The following is a description of a gene set: Human Gene Set: MIR3714 from publication Chen Y, Wang X (PMID 31504780) Genes predicted to be targets of miRBase v22 microRNA hsa-miR-3714 in miRDB v6.0 with MirTarget v4 prediction scores > 80 (high confidence targets). species: Homo sapiens, and this is the list of marker genes: ARNT2, RCOR1, NUFIP1, PARP16, SLC46A3, USP14, RBM39, ELAPOR2, APLF, HPGD, ELOVL1, SELENOI, SLC35D1 (NCBI Gene Id 23169), RYBP, DENND1B, RHBDL3, RNF216, TTL, SLC31A2, DESI1 (NCBI Gene Id 91610), CSNK1G1, CBLB, PAXBP1, MYO10, RWDD4, SETD3, TMED1, MYLIP, EXTL3 (NCBI Gene Id 2137), ZNF706, SLC9B2, DMD, PAPSS2, FKBP15, SPAG9 (sperm associated antigen 9), SLC4A8, MFSD14B, VAT1L, ADAMTS9, VAT1, THSD7B, ASCL1, BTG2, MTPN, CHSY1, PHACTR1, RALGPS2, PTHLH, ERMP1, FERMT2, QKI, CAPN2, CSTF3, TCTN3, AK4, THUMPD3, SURF4, ACSL1 (acyl-CoA synthetase long chain family member 1), ANXA7, PIEZO2, RTCB, BCL2L11, GPR158, SAP30L, HMBOX1, SEMA6A, NEMP2, PDLIM5, TMCC3, MCUR1, MC2R, GRID1, CBL (NCBI Gene Id 867), PTPN9, SLITRK6, FAM78A, SNX30 (NCBI Gene Id 401548), FIZ1, CACNB4, ZNF559, DCUN1D3, PTBP2, NOTCH1, SCP2, SH2B3, GK5 (NCBI Gene Id 256356), RBFOX2, GLT8D1, SCML4, CDKN2A, ZNRF3, DEPTOR, KATNA1, SLC50A1, SETBP1, ATMIN, GXYLT1, EPM2AIP1, RLIM, COL4A1, FBXO33, SLC9A6, RFX3, PABIR2, TXNDC9, UBR5, DPYSL2, MARK1, MYH9, JPH3, CCDC28A, FAM177A1, MYRIP, MTDH, PDE4A, ARHGAP32, RRM2, SLC11A2 (solute carrier family 11 member 2), ALG5, ODR4, SLC35B2, BTBD1, PROX1, CNTN1, PALM2AKAP2, CMTM7, SMAD2, IPO4 (importin 4), ASAP1, JAKMIP1, DIAPH1, KCTD8, HMGXB4 (HMG-box containing 4), WWC3 (NCBI Gene Id 55841), MAGT1, LIMCH1, CHST1, EFCAB14, KCNT2, EPHX4, CCDC50 (coiled-coil domain containing 50), TMEM178A, GOLM2, RAI14, STEAP2, PLXNB2, LPP, MACF1, SDAD1, LRRC1 (leucine rich repeat containing 1), RALA, TMTC3, ERF, SEC61A2, PALLD, CAPN6, TRIM36, DNAJC1, ZFAND5, AFF4, LRGUK, ZNF148, SLAIN2, BMP6, ARRDC4, LMNA, PTPN12, VANGL1, DCTN4, MPC1, MAN2A1, ST8SIA2 (ST8 alpha-N-acetyl-neuraminide alpha-2,8-sialyltransferase 2), SLC39A9, QDPR, TOR3A, SKAP1, MAPK14, TFDP2, BACH2, XYLT1, ATP6V0E1, TEAD1, OSBPL3, MAPK10, SLC4A7, CADPS, GLTP, KCNJ2, USP13, AIF1L (NCBI Gene Id 83543), FRAS1, SOX9, ADCY5, LYSMD3, TBL1XR1, WIPF2 (WAS/WASL interacting protein family member 2), IGDCC4, TRIB3, GPC4, ZNF561, ZNF608, GSS, NFIB, DESI2, OLFM2, MYO1C, SLC16A1, USP25, COMMD5, ALCAM, RELA, TMEM199, LMBRD2, ARPC5, DLL1, P4HA1, IQCJ (NCBI Gene Id 654502), PHTF2, SNX6, RAPGEF6, PRTG (protogenin), C1GALT1, APBB2, PRIMA1, KCNJ6, ATP8A1, SEMA6C, ATF7IP, PARD3, PTBP3, CYCS, HEPACAM, RAB27A, PRLR, SLC1A4, ADNP, CALN1, MARCHF8, TOR1AIP2, ELL2, SPRY3, MIGA1, ICMT, AMPH, GPR37, FNBP1L, TBC1D9B, LANCL1, SCAMP2, HRH1, SUCLG2, CD276, PPP1R13L, STT3A, FAM219B, ATF7, LITAF, SLC30A4, PGRMC2 (NCBI Gene Id 10424), HTR2C, ANTXR2 (ANTXR cell adhesion molecule 2), PCGF5, MLLT3, PIK3C2A, TPP1, PNN, LCP1, APH1A, GALNT13, EVI5, CCDC3, NAV1, MBOAT2, MMD, TCF3, MORC4, PRRX1, OLFM3, RPIA, MBP, C2orf88, ADRB2, BTD, PDS5A, NFATC1, CD164, SLC2A2, ROCK1, SF3A3, LPIN1, SLC26A9, PDCD6, MLANA, RHOU, FAM219A, MIER2, NR5A2, IKZF1, BCOR (BCL6 corepressor), ATP6V0A2, SUGT1, GRHL1, SNX18, EYA4, ADISSP, TANC2, RIMBP2, RBM20, CDK6, ARHGDIA, WASF1, AP1AR, TOX, CDK4, SCUBE3, FAM91A1, RDX, KLHL28, AHR, NEUROD1, PAPPA, JPH1, TMEM178B, TENM1, MLLT1, THRB, TARBP1, RAB43 (RAB43, member RAS oncogene family), PLEKHH1, SLC1A2, TMEM248, RGS9, MYNN, CREBRF (CREB3 regulatory factor, NCBI Gene Id 153222), COL12A1 (collagen type XII alpha 1 chain), LMAN2L, ELMO1, CUL5, ITPR3, GDAP2, ELK4, MTCL2, THSD4, CASP2, MYRF, ZDHHC3, PDXK, IQGAP1, SHTN1, GZF1, SERTAD3, LASP1, FLOT2, PEA15, PTBP1 (polypyrimidine tract binding protein 1), GIT2, TUBG1, LRRC15, ANKRD12, RASSF8, SLC10A7, ELAVL1, RAVER2, TMEM74, RING1, KCNK10, FBLN7, MECP2, MAPK4, TNS1, SMIM14, CTDSP2, SLC19A2, MOB3B, ULK2, FBXO10, CREB3L2, RHOQ (ras homolog family member Q), NR3C2, AHCYL2, MINAR1, DAAM2, SLC7A8 (solute carrier family 7 member 8), SIGMAR1, PID1, DIP2C, CDON, GAS1, EIF4A2, GLI3, MIER1, TLL1, EZH2, BTN2A2, CHP1, GSE1, MITF, LRRC58, ZNF503, ACAA2, CELSR3, SGSM2, ERLIN2, SNIP1, JADE2, FOXP1, FARP1, RBPJ, MTF1, PARP1, RERE, C1orf74, BTBD10, ANXA5 (NCBI Gene Id 308), SEC13, ANXA11, DCP1B, RPS6KB1, XKR6, FKBP1A, RCC1L (RCC1 like), AMOTL1, DYNLT3, BACE1, YIPF6, REEP1, SLC29A1, PLSCR3, SP1, GRM1, ELOVL5, CDKN1A, EPHA7, PAPOLG